The following is a description of a gene set: Human Gene Set: GSE411_WT_VS_SOCS3_KO_MACROPHAGE_IL6_STIM_400MIN_UP species: Homo sapiens Effects of SOCS3 on the transcriptional response of bone marrow-derived macrophages to IL-6. Fetal liver cells from SOCS3+/+ or SOCS3-/- embryos were used to reconstitute recipient mice. Donor derived bone marrow from these mice was differentiated to macrophages. Macrophages were either unstimulated, or stimulated for 100 or 400 minutes with 10 ng/ml IL-6. Genes up-regulated in macrophages treated by IL6 for 400min: wildtype versus SOCS3. from publication Lang R, Pauleau AL, Parganas E, Takahashi Y, Mages J, Ihle JN, Rutschman R, Murray PJ (PMID 12754506), and this is the list of marker genes: B3GNT7, NRP2, CYFIP1, PBX3, DNASE1L3, NAV2, SBF2, TNFRSF1B, MFHAS1, C15orf39, ANXA2, ZNF703, NECTIN1, RSRC2, CNST, NFATC1, RAPGEF5, KCNN4, TXN, CASP3, GOT1, SAMSN1, LIPC, DDX3X, SUB1, ERLIN1, CFP, ENPP1, SIRPA, CCR5, GLIPR2, AHCTF1, CSE1L, ILDR1, LCP2, FLNB, FSD2, STK17B, LACC1, REV3L, PMEPA1, MPEG1, USP38, CCDC40, SLC4A8, E2F8, SLC3A2, SRGAP3, S1PR3 (sphingosine-1-phosphate receptor 3), TMED5, AMZ1, MOCOS, TK1, KRT222, KLF4, PVT1, EHD1, PLAUR, MEIS3, TUBA1A, PSMA3, EHD3, DAD1 (NCBI Gene Id 1603), HSPA1B, IL10 (NCBI Gene Id 3586), BMI1, C21orf91, PLEK, UBE2K, ARL4A, JUNB, CCL5, TMEM51 (transmembrane protein 51), CLSTN1, SIAH2, UBAP2L, CHDH, TSPAN33, GTF2I, GSAP, HIC1, CD86, SOS2, CD300LF, USP34, GSTT2, CACNA1D (NCBI Gene Id 776), GCAT, CDH17, DYRK3, TJP2, LMO7, PBX4, ZBTB10, FDX1, TEX30, MLF1, ST6GALNAC3 (NCBI Gene Id 256435), GLA (galactosidase alpha), ST7, PLXNB2, DNAJA4, HS3ST1, GRAMD2B, TGIF2, VRK2, ATP6V1E1, CHCHD3, CLN6, SMYD2, ASB2, H2AZ1, GPR34, BASP1, PAXBP1, BCAR3, GPR171, DUSP1, CYP51A1, C19orf53, BPIFA3, RAPGEF2, TRIM62 (NCBI Gene Id 55223), LITAF (lipopolysaccharide induced TNF factor), CELSR1, FGL2, CACNA1S, BEX3, CAMKK1 (NCBI Gene Id 84254), MS4A7, RYK, MGAT4A, RAB43, RAB11FIP4, MKI67, RALGDS, TMX4, CDC14B, UBALD2, BAIAP2L1, TMEFF1 (NCBI Gene Id 8577), KCTD17, ARID5A, FAM89A, NEIL1, CASP4, BLTP1, EDEM1, ANKMY2, C8A, SQSTM1, NID1, ZBTB32, CDON, DUSP8, CHST7, UBXN2A, BEND3, GHITM, VPS37B (VPS37B subunit of ESCRT-I), PDE3B, TMEM176B, RILPL2, RNF138, NIBAN1 (NCBI Gene Id 63911), SLC12A2 (NCBI Gene Id 6558), NCOA7 (NCBI Gene Id 135112), KCNK6, CTNNAL1, ALPK2, MN1, ITM2C, PNPLA2, FAM227B, COQ10B (NCBI Gene Id 80219), SH2B2, ANKRD33B, PIK3CB, TBX21, RFTN1, IFNLR1, HSPA8, DOCK8 (dedicator of cytokinesis 8), HSPA2, ASNS, RGS10, ZC3H12C, CEBPB, DIAPH2 (diaphanous related formin 2), DNAJB2, RGCC, CD80, MAPK12, SHB, FNIP1, TPP2, MANEA, AHSP, HMGN3, PRKX